The following is a description of a gene set: Reactome Pathway: Defective F8 binding to the cell membrane part of: Defective factor VIII causes hemophilia A studied in species Homo sapiens, and this is the list of marker genes: F8